The following is a description of a gene set: Human Gene Set: GSE22886_NAIVE_VS_IGM_MEMORY_BCELL_UP Genes up-regulated in comparison of naive B cells versus memory IgM B cells. Immune cell-specific expression is one indication of the importance of a gene's role in the immune response. In order to identify such patterns, we set out to broadly profile gene expression in a variety of immune cells. species: Homo sapiens from publication Abbas AR, Baldwin D, Ma Y, Ouyang W, Gurney A, Martin F, Fong S, van Lookeren Campagne M, Godowski P, Williams PM, Chan AC, Clark HF (PMID 15789058), and this is the list of marker genes: ZNF43, PARG, HCN4, BBS4, YY2, SZT2, ASAP2, TREML2, SIAH2, CORO2B, CYP2C18, JPT2, MARCHF3, HKDC1, CYSLTR2, ABHD4, FBXO28, TENT5A, KLHL35, CCP110, RPUSD2, GPR12, ARIH1, FARP1, NRGN, CEMIP2, IL13RA1, PDE1B, H1-10, KRT2, RADX, ZNF235, LUZP4, TSPAN13, FCER1A, BCL7A, FAT1 (FAT atypical cadherin 1), RPAP1, HMGCS1, IL4R, GOLGA6A, IL21R, CDK19, NID1, GALNT3, FAM53B, IL9 (interleukin 9), SFRP1 (NCBI Gene Id 6422), P2RY14, SLC26A2 (solute carrier family 26 member 2), MST1, DDR1, STRN4, WWC3, GALNT6, LARGE1, LRCH1 (leucine rich repeats and calponin homology domain containing 1), CA14, ZW10, SLC2A10, DBNDD1, RARS2, EXOG, LAIR1, VAV3, TIMP4, TAAR2, NOD1, PLK2, PRCP, EIF1AY, ATP6V0A1, EPAS1, SOBP, RGL2, SCG2, SMAD3, RETREG1, BACE1, RPS2P45, STOM, SSBP2, ABCB1, SMURF1, DTX4, CHAT, KCNJ14 (potassium inwardly rectifying channel subfamily J member 14), CLCN4, LMO2 (LIM domain only 2), SATB1, WWOX, DGKD, HEYL, TMOD1, SLC35E3, GABBR1, UXS1, AGGF1, SYT17, ASB1, DDX28, MMP17, FBXO4, IGHD, TSPAN32, SESN1, FCGBP, ZHX3, ADARB1, CD200, GTF3C4, FAM8A1, ESS2, OGFOD3, LDHC, UGDH, SORL1, PCDH9, YBX3, P2RX1, TPD52L1, CYB561, FAM171A1, USP2 (ubiquitin specific peptidase 2), DHX9-AS1, GSTA4, SLC10A1, TSFM, SLC4A8, MAB21L1, LCOR, SLC30A4, TENM1, JPH3, SLAMF1 (signaling lymphocytic activation molecule family member 1, NCBI Gene Id 6504), DNMBP, PRDM10, CCDC181, UTRN, SCN3A, LYST, FMO5 (NCBI Gene Id 2330), TRMT12, XKR8, PLPBP, CXCR4, ACVR2B, SLC45A2, GCNT1, ATP11A, NRF1, RFPL3, PDP1, KLF7, EXOC7, TIMELESS, CXCL1, DCAF17, DSP, TRIB2, TOMM34 (NCBI Gene Id 95099), RASGRF1, SPRY4, CD302, SLC39A4, PIK3C2B, EDNRA, ZBTB16, KCNJ9, SKAP1, RFTN1, SOCS1, AOX1, UCP1, RHOC, SCLY, DPYD, KIR2DL5A, KIFBP, AURKC, NEIL1, TPST1, MCTP2, RASL10A, TBC1D13 (NCBI Gene Id 54662), DOCK5, PVT1, HCFC2, CXCL13, MAVS, SPRY1, RSL1D1, FCER1G, APLP2, PSMB2, ANKRD55, FOXO1